The following is a description of a gene set: studied in species Mus musculus A structural network of microtubule inner proteins (MIPs) located inside the lumen of the B tubule of the axonemal microtubule doublet that helps stabilize the B tubule. Mouse Gene Set: GOCC_AXONEMAL_B_TUBULE_INNER_SHEATH, and this is the list of marker genes: Cfap52, Cfap45, Tektl1, Pacrg, Cfap77, Cfap144, Cfap90, Cfap276, Cfap126, Cfap210, Spmip10, Cfap20, Enkur